The following is a description of a gene set: species: Homo sapiens Human Gene Set: GOBP_SEMAPHORIN_PLEXIN_SIGNALING_PATHWAY The series of molecular signals generated as a consequence of a semaphorin receptor (composed of a plexin and a neurophilin) binding to a semaphorin ligand., and this is the list of marker genes: NRP2, RAC1, SEMA4B, SEMA4G, PLXNA4, SEMA5A, SEMA5B, PLXNB1, SEMA4A, SEMA3D, SEMA6B, SEMA6A, HAND2, ERBB2, MET, SEMA7A, SEMA6D, PLXND1, SEMA3A, RHOA, SEMA3G, FARP2, ARHGDIA, EDNRA, EDN1, CRMP1, SEMA4F, SEMA3E, SEMA6C, GDNF, PLXNB2, SEMA3B, TYROBP (NCBI Gene Id 7305), PLXNA1, PLXNA3, SH3BP1, SEMA4D, SEMA4C, PLXNC1, NCAM1, TREM2, NRP1, SEMA3C, PLXNB3, FLNA, ECE1, KDR (kinase insert domain receptor), SEMA3F, PLXNA2